The following is a description of a gene set: Genes for which mutations result in developmental defects in the great vessels formation and valvulogenesis, a major class of congenital heart disease. Human Gene Set: BRUNEAU_HEART_GREAT_VESSELS_AND_VALVULOGENESIS Congenital heart disease is the leading cause of infant morbidity in the Western world, but only in the past ten years has its aetiology been understood. Recent studies have uncovered the genetic basis for some common forms of the disease and provide new insight into how the heart develops and how dysregulation of heart development leads to disease. from publication Bruneau BG (PMID 18288184) studied in species Homo sapiens, and this is the list of marker genes: PTPN11, NKX2-5, NOTCH2, TFAP2B, JAG1, TBX1, NOTCH1, MED13L